Given this list of marker genes CCL8, EIF2AK4, PRKN, CCNK, MIR221, SMC6, ZBED1, SMC5, MIR222, ZC3H12A, PSMC3, LTF, VAPB, APOBEC3H, APCS, VAPA, PTX3, here is a description of the gene set: A process in which a host organism stops, prevents or reduces the frequency, rate or extent of a process being mediated by a virus with which it is infected. Human Gene Set: GOBP_NEGATIVE_REGULATION_BY_HOST_OF_VIRAL_PROCESS species: Homo sapiens